The following is a description of a gene set: The ternary complex factor Net/Elk3 is downregulated in hypoxia and participates in the induction by hypoxia of several genes, including c-fos, vascular endothelial growth factor and egr-1. However, the global role of Net in hypoxia remains to be elucidated. We have identified, in a large-scale analysis of RNA expression using microarrays, more than genes that are regulated by Net in hypoxia. In order to gain insights into the role of Net in hypoxia, we have analysed in parallel the genes regulated by HIF-1alpha, the classical factor involved in the response to hypoxia. We identified about genes that are regulated by HIF-1alpha in hypoxia. Surprisingly, when we compare the genes induced by hypoxia that require either Net or HIF-1alpha, the majority are the same (75%), suggesting that the functions of both factors are closely linked. Interestingly, in hypoxia, Net regulates the expression of several genes known to control HIF-1alpha stability, including PHD2, PHD3 and Siah2, suggesting that Net regulates the stability of HIF-1alpha. We found that inhibition of Net by RNAi leads to decreased HIF-1alpha expression at the protein level in hypoxia. These results indicate that Net participates in the transcriptional response to hypoxia by regulation of HIF-1alpha protein stability. Genes specifically down-regulated in SEND cells (skin endothelium) at hypoxia after knockdown of ELK3 by RNAi. species: Mus musculus Mouse Gene Set: GROSS_HYPOXIA_VIA_ELK3_ONLY_DN from publication Gross C, Dubois-Pot H, Wasylyk B (PMID 17704799), and this is the list of marker genes: Ppargc1b, Ncbp2, Trim8, Arrb1, Csf3, Nfic, Nde1, Igfbp4, Cdkn2c, Minpp1, Marcks, S100a4, Chek2, Racgap1, Nav1, Mknk2, Cbx6, Kif23, Zbtb14, Pdrg1, Nrep, Stmn1, Cenpa, Ei24, Brd3, Eif2ak2, Kcp, St3gal4, Abcg1, Cldn15, Pald1 (phosphatase domain containing, paladin 1), Lama5, Trp53inp1, Sipa1, Aox1, Fasn, Ubox5, Dok4, Pxdn, Mapk14, Hoxd9, Cdc25b, Mafb, Lmo2